The following is a description of a gene set: The synthesis of aminoacyl tRNA by the formation of an ester bond between the 3'-hydroxyl group of the most 3' adenosine of the tRNA, to be used in ribosome-mediated polypeptide synthesis in a mitochondrion. studied in species Mus musculus Mouse Gene Set: GOBP_TRNA_AMINOACYLATION_FOR_MITOCHONDRIAL_PROTEIN_TRANSLATION, and this is the list of marker genes: Yars2, Ears2, Gars1 (NCBI Gene Id 353172), Dars2, Wars2, Aars2, Sars2